The following is a description of a gene set: Human Gene Set: GOBP_CARDIAC_CONDUCTION studied in species Homo sapiens Transfer of an organized electrical impulse across the heart to coordinate the contraction of cardiac muscles. The process begins with generation of an action potential (in the sinoatrial node (SA) in humans) and ends with a change in the rate, frequency, or extent of the contraction of the heart muscles., and this is the list of marker genes: AGT, MIR208A, TNNI3K, MIR1-1, TRPM4, DSC2, NUP155, SCN5A, TMEM65, ZMPSTE24, CACNA1C, CXADR (NCBI Gene Id 95792), TBX18 (T-box transcription factor 18), KCNH2, EHD3, MEF2A (NCBI Gene Id 4205), HCN3, ATP1B2, ATP2A2, KCNJ3, FLNA, PLN, KCNQ1, SLC8A3 (NCBI Gene Id 90450), KCNJ5, ATP2B2, SPTBN4, KCNJ2, PKP2, CACNA1D, ACE2, ATP1A1, GJA1, SCN4B, GJA5, KCNE3, CALM2, BIN1, GJD3, HCN4, IRX3, PRKACA, SCN10A, SRC, RYR2, KCNH6, DSP, CACNB2, ATP2B1, SCN2B, ATP2B4, ABCC9, MIR328, TRPC1, ACE, KCNE4, CORIN, DSG2, ATP1A2, TRDN, AKAP9 (A-kinase anchoring protein 9), HRC, CACNA2D1, GJC1, PDE4D, RANGRF, SRI, KCND3 (potassium voltage-gated channel subfamily D member 3), NKX2-5, GJC3, YWHAE, KCNE2, KCNA5, SCN1B, ISL1, SCN3B, CALM3, ATP1A3, CASQ2, ATP2A1, CAV1, KCNE5, JUP, CTNNA3, CACNA1G, HCN1, ATP1B1, ANK2, SLC9A1, SLC4A3, TBX5, SLC8A1, ATP2B3, MIR19A, CAMK2D, KCNN2, ATP2A3, SLC8A2, KCNE1, CALM1